The following is a description of a gene set: Lack of measurable response to stimulation of auditory evoked potentials. studied in species Homo sapiens Absent brainstem auditory responses Human Gene Set: HP_ABSENT_BRAINSTEM_AUDITORY_RESPONSES, and this is the list of marker genes: SPTBN4, KARS1, TIMM8A, ERCC8, OPA1, RIPOR2, ERCC4, OTOF, MOGS, NEFL (NCBI Gene Id 4747), SOX10 (NCBI Gene Id 8223), ERCC6